The following is a description of a gene set: Mouse Gene Set: GOBP_DNA_GEOMETRIC_CHANGE The process in which a transformation is induced in the geometry of a DNA double helix, resulting in a change in twist, writhe, or both, but with no change in linking number. Includes the unwinding of double-stranded DNA by helicases. studied in species Mus musculus, and this is the list of marker genes: Hmgb1, Wrn, Blm, Recql, Mterf1b, Hmgb3, Mterf1a